The following is a description of a gene set: Human Gene Set: GOBP_REGULATION_OF_NEUROGENESIS species: Homo sapiens Any process that modulates the frequency, rate or extent of neurogenesis, the generation of cells in the nervous system., and this is the list of marker genes: TRPC5, PCM1, SEMA4F, SKIL, CDK5, SEMA3F, CAMK2B, TP53, IL1RAPL1, MIR222, WNT5A, LYN, RB1, NOS1, CDH4, SPINT1, PTN, ADNP, SS18L1, CDH1, TSPO, MTOR, KIAA0319, SYNGAP1, VEGFA, MIR181B1, SNW1, XRCC2, CERS2, SHH, GPER1, WNT3, KDM1A, LIN28A, IDH2, PPP1CC, GSX2, CX3CR1, VSX2, DLL3, NTN1, NAP1L1, TRIM32, SIRT2, EPHA7, ZNF365, DCC, PRTG, SEMA6D, HES5, YWHAH, TNFRSF1B, NOTCH1, CTDSP1, CAPRIN1, CUX2, CAPRIN2, GPR37L1, SERPINF1, HEYL, FZD3, IL34, RUFY3, TBC1D24, REST, L1CAM, DUSP10, SLIT2, ASCL1, MAP1B, TIAM2, MAG, HES1, TGM2, HES2, SPP1, ROBO2, YTHDF2, MAP2K1, DIP2B, MIR146A, EFNA5, FXR2, GOLGA4, RNF112, FEZF2, SPEN, IL6ST, OLIG2, BCL11A (NCBI Gene Id 55085), MYCN, MAP6, HES3, TREM2, CLCF1, HLTF, METRN, SOX11, PLXNB3, NF1, FBXW8, BRINP1, MIR125B1, KIT, NFATC4, TNF, APPL2, MYB, NKX6-2, BRAF, HELT, SOX10, DAAM2, DLL4, TGFB1, FSTL4, DNAJB11, RGS14, FMR1, SEMA4D, PAX6, GATA2, EPHB2, QKI, HOXB3, LHX2, RNF10, NUMB, AMIGO1, DLX1, HMGB2, DRD3, EEF2K, CXCL12, BHLHE40, TENM4, MAP2K2, TNFRSF12A, NIN, FGF13, PAFAH1B1, CDKL5, PARP6, ROBO1, KRAS, IST1, STAU2, CHD7, MIR181C, RND2, LRP4, SERPINE2, HEY2, DLL1, NR1D1, TRIM11, SMARCD3, MIR137, FERD3L, WNT3A, ELL3, BMP2, SMO, VEGFC, RASSF10, BMPR2, LIMK1, ULK2, PLXNC1, CUX1, HEY1, PTEN, ATXN1, POU4F1, PTPRD, ETV5, SLIT1, SHTN1, EGR2, XRCC5, NOG, HMGA2, SEMA6C, MIR221, CLCN2, FOXG1, CDKL3 (cyclin dependent kinase like 3), VAX1, SOX8, BMPR1A, TNR, MAPT, PLXNB1, CTNNB1, FZD4, PSEN1, CRABP2, LPAR3, MYRF, PLXND1, HAP1, RYK, RTN4R, TWF2, SHOX2, MACF1, RGMA, MAP2, SLC7A5 (solute carrier family 7 member 5), RELA, PROX1, CXCR4, CDON, SEMA5A, LRP2, NR2E1, SRRT (NCBI Gene Id 51593), CTNNA1, POU4F2, DYNLT1, PRKCI, DLX2, TRPC6, GRM5, GORASP1, OPRM1, WDR62, PLAG1, ANAPC2, PAK1, SEMA3G, B2M, HES7, WNT2, MIR142, MDK, RNF6, RAPGEF2, PER2, ASCL2, MAP3K13, TRPV2, NRDC, PTPRZ1, DISC1, SPART, NEURL1, WNT7A, E2F1, YAP1, TRIM46, ISLR2, BIN1, STK11, NTRK2, BDNF (brain derived neurotrophic factor), BHLHE41, BMP7, PLXNB2, RTN4, EFNB3, GPRASP3, NKX2-2, ZEB2, KHDC3L, ITPKA, NEFL, SEMA7A, OBSL1, CCL11, LRP8, DPYSL5, NRP1, ULK1, KCTD11, LTA, THY1, ADCY10, ANXA2, DRAXIN, BMAL1, LIG4, TTBK1, GDI1, DOCK7, MAN2A1, TRAK1, ID2, IFNG, DRD2, STK25, MECP2, HDAC6, NTRK3, GLI3, SRF, PRUNE1, BTG2, DAG1, ABCC8 (ATP binding cassette subfamily C member 8), ID4, PPP3CA (NCBI Gene Id 5530), SHANK3 (SH3 and multiple ankyrin repeat domains 3), CUL7, IL6, SYT4, KIFAP3, HDAC2, FXR1, LIF, ARHGAP4, SORL1, TMEM98, F2, CX3CL1, MCF2, PRKCH, EPHA4, HOOK3, TP73, FEZF1, ARMCX5-GPRASP2, DAB1, SLC30A1, RAB21 (NCBI Gene Id 23011), PTPRS, RELN, DBN1, ZNF488, NPTN, S100A10, CHODL, DSCAM, UFL1, DICER1, EZH2, ZNF335, BAIAP2, NUMBL, LDLR, NF2, MEGF8, PITX3, NGF, FGF2, DCT (dopachrome tautomerase), RHEB, DHX36, OTP, HIF1A, LEF1, MME, PLXNA3, ANKRD27, NKX6-1, GFAP, IFRD1, SLITRK1, DMRTA2, TLX2 (NCBI Gene Id 51407), ZFYVE27, TIAM1, ITGB1, PRMT5, SKI, TRAK2, ASPM, SMURF1, IL1B, ATOH1, FN1 (fibronectin 1), HES6, HDAC1, MT3